Given this list of marker genes CACNA1H, SLC2A1, FMO3, DGCR8, GABRB3, TP63, USP48, GABRA1, IMPA1, GABRG2, IRF6, PPOX, ATRX, ECM1, BRAF, MSX1, SNCA, CDH23, VPS13A, TP53, TBP, JRK, NECTIN1, CPOX, PRDM8, ESS2, PLA2G6, TBX1 (NCBI Gene Id 7413), HMBS, NR3C1, DGCR2, DGCR6, TIMM8A, USP8, here is a description of the gene set: Human Gene Set: HP_COGNITIVE_DISTORTION Cognitive distortion studied in species Homo sapiens A cognitive distortion is a maladaptive, exaggerated, or irrational thought pattern.